The following is a description of a gene set: species: Mus musculus A process that is carried out at the cellular level which results in the assembly, arrangement of constituent parts, or disassembly of the kinetochore, a multisubunit complex that is located at the centromeric region of DNA and provides an attachment point for the spindle microtubules. Mouse Gene Set: GOBP_KINETOCHORE_ORGANIZATION, and this is the list of marker genes: Smc4, Pogz, Cenpw, Smc2, Cenpx, Sugt1, Rnf4, Mis12, Trappc12, Cenpc1, Nuf2, Kntc1, Dlgap5 (NCBI Gene Id 97934), Cenph, Ndc80, Cenpk, Cenpe, Senp6, Cenpt, Cenpa